The following is a description of a gene set: Genes predicted to be targets of miRBase v22 microRNA hsa-miR-6086 in miRDB v6.0 with MirTarget v4 prediction scores > 80 (high confidence targets). studied in species Homo sapiens Human Gene Set: MIR6086 from publication Chen Y, Wang X (PMID 31504780), and this is the list of marker genes: ZC3H4, ADGRB3, ZNF234, AGO1, ACER2, PSG7, TMEM30B, FKBP1A, PAPOLA, TRIO, CDH10, EPO, ROBO1, TRPM7, TEX56P, CDK14, ANGPTL4, TFPI, ZNF483, MYO5C, DDA1, PSG1, FBN3, NCOA1, PRRC1, ASIC1 (NCBI Gene Id 41), ACBD5, PITPNM2, MSL2, TMEM167A, NCOR1, PSG4, SLC37A3, MYEF2, TSPYL1, HTR4, FKBP5, SYT11, ZNF273 (zinc finger protein 273), ACAT2, ARRB2, ZFP82, KRTAP8-1, MTX2, LAMP5, BATF2 (basic leucine zipper ATF-like transcription factor 2), EIF5A2, FBN2, CHTF8, CCDC89